Given this list of marker genes SNX4, VAMP3, VAMP2, VAMP8, SNX6, VAMP7, PLA2G3, here is a description of the gene set: studied in species Homo sapiens Human Gene Set: GOBP_REGULATION_OF_HISTAMINE_SECRETION_BY_MAST_CELL Any process that modulates the frequency, rate or extent of histamine secretion by mast cell.